Given this list of marker genes EIF2B1 (NCBI Gene Id 1967), CYP27A1, PLA2G6, SLC25A13, CSF1R, PPP2R2B, DRD3, MTHFR (methylenetetrahydrofolate reductase), COMT, HTR2A, APOL2, HTT, RTN4R, MAN2B1, APOL4, PRNP (NCBI Gene Id 96713), CHI3L1, SLC2A3, HTRA1, PSAP, ARSA, C9orf72, DAOA, SNCB, TRANK1, SYN2, JPH3, SNCA, GBA1, HLA-DQB1, here is a description of the gene set: studied in species Homo sapiens Delusion Human Gene Set: HP_DELUSION A delusion is a fixed false belief held despite evidence to the contrary. The term delusion broadly encompasses all false judgments that possess the following external characteristics to a significant, albeit unspecified, extent: (1) they are held with an exceptional level of conviction, accompanied by an unparalleled subjective certainty; (2) there is an inability to consider alternative experiences or compelling counter-arguments; (3) the content of the belief is impossible.